Given this list of marker genes DCTN2, TUBGCP3 (NCBI Gene Id 10426), SDCCAG8, NFE2L2, TACC2, MECP2, RUVBL2, PJA2, PLK4, CSTPP1, PKHD1, USH1G, TPGS2, PRKACB, CCDC112, IFT56, FANCE, HAUS6, ZNF12, CEP83, SKP1 (NCBI Gene Id 6500), ARHGEF10, AHI1, CFAP184, NDRG1, CNTLN, PSKH1, AKAP9, CCDC38, CCNB1, ERCC6L2, KIFC3, PSEN2, RAB11A, BCL2L1, RAD51D, IFT22, RBM39, CEP295, TTC28, ENTR1, ATF3, UXT, TRAPPC14, DYNLRB2 (NCBI Gene Id 83657), ANKS1B, CDK5RAP2, CFAP263, RASSF1, CETN2, CBY1, LRRC45, CDK6, TPGS1, ATP6V1D (ATPase H+ transporting V1 subunit D), C10orf90, CHD3, PACSIN2, DCTN1, BRCA2, CTDP1, MAPK1, TTC12, CEP350, BNIP2, USP9X, HIPK1, BIRC7, CROCC, ODF2, CKAP5, PDZD2, TRAT1, STK3, SPPL2B (NCBI Gene Id 63937), SNCG, CCDC146, DYNC1H1, DYNC1LI1, SNX10, BICD1, CFAP298, UVRAG, RBBP6, SEMA4D, XRCC2, PDE4B, ENKD1, FRY, CCP110 (NCBI Gene Id 9738), RILPL2, TSEN2, TTC23L, RGS14, CYLD, PPP4C, SPAST, HOOK3, KIF15, MARCHF7, MAP2K1, TAP1 (NCBI Gene Id 92050), GRB2, RAB8A, IFT27, DBH, STX1B, NCAPD2, PIK3R5, MPLKIP, USP50, CCNF, NEIL1, NDC80, TBC1D31, NUMA1, IFT52, NFS1, CFAP53, MZT2A, CCDC92, CDK2, EXOC7, MPHOSPH9, SGO1 (NCBI Gene Id 151648), GIT1, CENPJ, SPAG5, DCTN3, ITGB1BP1, RABL2B, TRIM69, NINL, CAMSAP2, CEP192, ATM, DYNC1I2, NIN (NCBI Gene Id 57681), OBSL1, DENND1C, PRKAR1A, CCDC85B (NCBI Gene Id 11007), PRKAR2A, KIF3B, PPP4R2, NEK8, FBXL7, NAA40, ACTR8, CALM1, CEP20, CLTC, ACTR1A, CABCOCO1, KATNAL1, ANKRD45, MTUS2, KATNIP, RILPL1, PPP2R5A, CEP97, DYNC2I2, BUD31, KHDC3L, BICDL1, CKAP2, ATP6V0D1, GPR174, VPS4B, HOOK2 (hook microtubule tethering protein 2), TRAF5, CDC16, HYLS1, ASPM (NCBI Gene Id 93990), CCDC18, CCDC22, CNTROB, KIFAP3, AK6, CDKN1B, NUDT21, CEP128, HARBI1, AJUBA, MAP3K11, TUBGCP2, KLHL22, HAUS2, HSPA1A, PPP2R3C, PAX2, MTUS1, GPSM2, ALPK1, BBS5, CCDC15, MZT2B, KRT18, HAUS3, TUBGCP5, TXNDC9, ECPAS, AXIN2, IQSEC1, RABL6, DNAI1 (dynein axonemal intermediate chain 1), GNAI2, CSAG1, CCNO, CSNK1A1, ECT2, ARL2, LATS1, SSNA1, CCDC57, PTPN20, LCK, KNSTRN, KATNA1, DISC1, PRKACA, KIFC1, FLOT1, NIT2 (NCBI Gene Id 56954), B9D1, WDR35, ZFYVE19, TRAF3IP1, FAM110C, CDC27, ABRAXAS2, EMD, SPMIP4 (NCBI Gene Id 136895), HOOK1, RAB34, SPAG9, BRSK1, PLAG1, CEP250, RPS7, KIAA1217, HSPA1B, MAP7D1, ATF4, CALML3, TNKS2, HDAC6, TMEM201, CEP41, TOPBP1, SLAIN2, CEP68, OFD1, DIAPH1, DPF2, ARL3, CCNB2, PPP1R35 (protein phosphatase 1 regulatory subunit 35), PATJ, IL4R, SPATC1L, PLK5, NEK6, PSMB5, PTPN23, BOD1L2, CEP55, DNM2, PTK2, HSF1, NEK7, ILK, CAPRIN2, NUP62, TTC19, IST1, ZMYND10, RPGR, POC5, TUBE1, CLASP2, MME, MIB1, CEP19, NR0B1, KIAA0586, RPP25, MARK4, SEPTIN1, KIF5B, CD86, CCT5, BICD2, KLHL12, CCDC116, TRIOBP, C2CD5 (C2 calcium dependent domain containing 5), PLK3, STEEP1, MAP10, CEP78, NPHP4, ZNF365, PPP1R12A, KIF2B (kinesin family member 2B, NCBI Gene Id 84643), CEP126, CSPP1, FLCN, CDK5RAP3, TMEM63A, RABGAP1, SSX2IP, CEP120, CDC42, KAT2A, SCYL1, RRP7A, IFT74, CEP112, DTX4, SLC18A2, RPGRIP1L, HAP1, STK11, VPS4A, RGCC, HNRNPU, CEP70, MASTL, LIMK2, BRAF, ERC1, EYS, IFT43, RLBP1, RAD51, CFAP96, CC2D1A, PRKCQ, NUBP2, WRAP73, RUVBL1, GLE1, CKAP2L, MKKS, IFT140, HEPACAM2, ACTR1B, CEP295NL, DYNC2I1, PDCD6IP (programmed cell death 6 interacting protein), CD2AP, AKNA, IFT20, ZNF322, NDE1, TSG101, GSK3B, PRPF6, SLC1A4 (NCBI Gene Id 6509), TCEA2, SLF1, TTC8, PIBF1, TMUB1, NEK1, CEP131, DCTN4, UNC119, LCA5, DIS3L, KIF13A, APC, POC1A, TGIF2, CCDC28B, DYNLT2B, CEP290, DCAF12, FCMR, LRRCC1, GPAA1, CCDC141, CCDC13, CHEK1, ITSN2, TCHP, NDEL1, BCCIP, ALDOB, CCDC77, DDX3X, TRIM32 (tripartite motif containing 32), NDN, TEK, FEZ1, PAFAH1B1, CNTRL, FAM184A, YPEL5, DYRK3, UNC5CL, MLLT11, ODF1, FSD1, EPS8L2, WDR13, SCLT1 (sodium channel and clathrin linker 1), RIC8B, MAPRE1, KIF3A, DDHD2, CEP76 (NCBI Gene Id 79959), CAPN7, CEP135, SLC8A3, MAMLD1, AGTPBP1, STIL, LHCGR, CDKL2, CEP43, IFT81, RAB11FIP4, SPDL1, GLI2, CENPF, DZANK1, LRWD1, DYSF, PSEN1, UBXN2B, PDE4D (phosphodiesterase 4D), RANBP1, MAD1L1, MVB12A, WRN, CLUAP1, NUBP1, CCDC187, PPP1R42, PROSER3, SMAD4, DCTN5, NLRC3, EFHC1, MAK, CADPS2, CEP152, CEP85L, CDC20, HAUS1, HASPIN, CEP95, FBF1, SPOUT1, TUBGCP4, CCDC124, FIGN, FAM110B, KIF20B, CCDC61, JADE1, DLGAP5 (DLG associated protein 5), CETN1, DRD4, CLIC5, RABEP2, SMAD7, AAAS, YES1, PCLAF, USP33, IL1RN, ATF5, RTTN, TTC39A, CEP162, OCRL, NEK2, PPP4R3B, GEN1, PBOV1, CLIC4, MARCKS, MISP, SLC16A1, ARFGEF2, CEP44, HAUS4, TRIM43, AUNIP, ANKRD26, DYNLL2, CCDC14, RITA1, RNF19A, CENPU, ZBED6, EYA3, CTAG2, EXOC4, PCNA, AKAP11, TCP1, LEO1 (LEO1 homolog, Paf1/RNA polymerase II complex component), CYTH4, CCT4, RAB11FIP5, HORMAD2, DCLRE1B, RASSF7, MAGI2, WDR90, CALM2, PHF1, SLC1A5, NSFL1C, LRIF1, C2CD3, BUB1B, KMT2E (lysine methyltransferase 2E (inactive)), ROCK2, KEAP1, DYNC1LI2, CAMK2B, HMBOX1, SPATC1, LUZP1, DAPK3, DCAF13, BLOC1S2, ODF2L, CHD4, CTNNB1, CCDC66, ARHGEF7, CDKL5, FBXL13, FNIP2, FBXW11, APOBR, UBR4, CDK1, HK2, ALS2, KIAA0753, RAP1GAP2, ZFYVE26, ORC2, BBS9, RAB6C, RASSF10, CFAP58, RTRAF, IFT25, UPF3B, SPICE1, MCPH1, RAB11FIP3, FLII, LZTS2, B9D2, SASS6, USP20 (NCBI Gene Id 10868), CTNNBL1, RRAGD, CCDC88A, PODXL, TBCD, TENT5C, AURKA, CEP63, TBCCD1, LRRC49, NPM1, ESPL1, KIF24, TMEM67, CDH23, SNAP29, WDR62, TACC1, MCRS1, PCNT, PKN2, CEP164, CDC45, DYNLL1, DYRK1A, IFT46, BBS2, MID1, EEF1AKMT3, MDM2, HOXB4, PLEKHG6, JTB, NUP93, MFAP1, KIZ, CIB1, IFT80, GNAI1, SORBS1, IFT57, DYNC2LI1, PDE4DIP, AURKB, CDC42BPG, CEP57, NCKAP5L, TACC3, MPP1, SAC3D1, E2F1, MAP1S (microtubule associated protein 1S), CROCC2, NR3C1, UBXN6, LATS2, PPP4R3A, TNKS, KMT5B, MZT1, KIF2C, IRAG2, PDIA6, BCAS2, NUDCD2, GPRC5C, BBS1, CIP2A (cellular inhibitor of PP2A), AURKC, BBS4, CCSAP, PLEKHA7, MKS1, DDX11, RAB23, CTSC, GNAI3, VPS37A, NEDD1, IQCB1, CENATAC, KIF23, YTHDF2, DYNLRB1, TRIP4, TP73, CUL3, KAT2B, HAUS7, BOD1, CEP72, TEX9, FAM161A, CSNK1D, CCDC88B, ASAP1, DCTN6, ANKRD7, NAA11, KIF18A, CCDC88C, IFT88, FRMD8, DZIP1, MYOF, TAF1D, CRMP1, ALMS1, CALM3, CCT8, CCDC8, ILRUN, PSMA1, STOX1, SKA1, POLR3H, RAPGEF6, RELB, MDH1, MAP7D2, DCAF1, RRM1, TTLL5, G6PD, CCDC81, EVI5, CETN3, PARP3, SERINC5, HNMT, RAC1, RAB3IP, RAD18 (NCBI Gene Id 56852), FAM110A, MMS19, MAPKAPK2, KATNB1, TESK1, HAUS8 (NCBI Gene Id 93323), POC1B, SKA3 (spindle and kinetochore associated complex subunit 3), KIF2A, RAPSN, DHX9, SAXO1, CIR1, PRKAR2B, HAUS5, NLRC5, CEP104, SFR1, PCM1, TUBGCP6, UBN1, NME7, BRSK2 (NCBI Gene Id 9024), CUL7, TTLL12, PLK2, CLASP1, SNTB2 (syntrophin beta 2), CEP89, MDM1, PLK1 (polo like kinase 1), PCGF5, KIF25, SIRT2, PAK1, OLA1, AK5, CREB1, IVL, CEP170, USP2, TUBG1, CEP85, SKI, SLMAP, DTL, TAPT1, PXK, NEK9, BIRC6, TP53, PROCR, PARD6A, BBS7, ZBED1, HMMR, ARL2BP, TUBG2, CHODL (NCBI Gene Id 84535), CEP57L1, APEX1, KLHL4, CCDC42, CAMSAP3, CLIP1, CDC14A, CDC25B (cell division cycle 25B), H2AX, here is a description of the gene set: A structure comprised of a core structure (in most organisms, a pair of centrioles) and peripheral material from which a microtubule-based structure, such as a spindle apparatus, is organized. Centrosomes occur close to the nucleus during interphase in many eukaryotic cells, though in animal cells it changes continually during the cell-division cycle. studied in species Homo sapiens Human Gene Set: GOCC_CENTROSOME